Given this list of marker genes Chchd6, Micos10, Apoo, Immt, Chchd3, Chchd10, Apool, Dnajc11, Micos13, here is a description of the gene set: Mitochondrial inner membrane complex involved in maintenance of crista junctions, inner membrane architecture, and formation of contact sites to the outer membrane. In Saccharomyces cerevisiae the complex has six subunits: MIC10, MIC12, MIC19, MIC26, MIC27, and MIC60. Mouse Gene Set: GOCC_MICOS_COMPLEX studied in species Mus musculus